Given this list of marker genes SELENOM, IGLV3-1, MAN1A2, IGLC5, IGLC6, HLA-F, DNAJB9, SEL1L3, IGLC2, KLF6, CD27, IGHG1, DERL3, IGHA1, CD79A, CD63, CITED2, IGHM, TSC22D3, JCHAIN (NCBI Gene Id 3512), CCPG1, IRF4, IGLV3-21, FCRL5, IGKV4-1, JSRP1, IGLC7, IGKV1-12, IGKC, IGHG4, IGHG2, TNFRSF17, TXNIP, ADA2, IGLJ1, IGHGP, HERPUD1, PRDX4, IGLJ3, ITGB7, IGLV3-7, IGHG3, IGHA2, IGLC3 (immunoglobulin lambda constant 3 (Kern-Oz+ marker)), IGLJ2, IGLL5, IGLC1, MIR4539, IGLV6-57, here is a description of the gene set: Human Gene Set: GAVISH_3CA_MALIGNANT_METAPROGRAM_36_IG studied in species Homo sapiens In this study, an extensive analysis was conducted to define meta-programs (MPs) capturing intra-tumor heterogeneity across a spectrum of tumor types. The approach utilized non-negative matrix factorization (NMF) to analyze each cell type separately within individual tumor samples. This involved the analysis of malignant cells, macrophages, fibroblasts, endothelial cells, epithelial cells, T-cells, and B-cells. NMF was executed with varying parameter values (K=4, 5, 6, 7, 8, 9), thereby generating 39 programs for each cell type per sample. Each NMF program was summarized by the top genes based on NMF coefficients.\nRobust MPs were then delineated for each cell type using a set of stringent criteria, including recurrence within the same tumor, similarity to programs in other tumors, and non-redundancy within a tumor. Subsequently, these robust NMF programs were clustered (per cell type) based on Jaccard similarity, leading to the identification of MPs associated with each cell type.\nTo enhance the quality of the MPs, a refinement steps were undertaken, involving the removal of MPs suspected of reflecting low-quality data (with an overrepresentation of ribosomal proteins or mitochondrial-encoded genes), single-study inclusion, or similarity to miss-annotated cell types. from publication Gavish A, Tyler M, Greenwald AC, Hoefflin R, Simkin D, Tschernichovsky R, Galili Darnell N, Somech E, Barbolin C, Antman T, Kovarsky D, Barrett T, Gonzalez Castro LN, Halder D, Chanoch-Myers R, Laffy J, Mints M, Wider A, Tal R, Spitzer A, Hara T, Raitses-Gurevich M, Stossel C, Golan T, Tirosh A, Suvà ML, Puram SV, Tirosh I (PMID 37258682) Genes upregulated in subsets of cells of a given type within various tumors